The following is a description of a gene set: A series of reactions in which a signal is passed on to downstream proteins within the cell via HRI (also known as EIF2AK1), an intracellular protein kinase that is activated by stress signals, such as heme deficiency, oxidative stress, osmotic shock, mitochondrial dysfunction and heat shock. species: Mus musculus Mouse Gene Set: GOBP_HRI_MEDIATED_SIGNALING, and this is the list of marker genes: Ddit3, Oma1, Atad3a, Eif2s1, Dele1 (NCBI Gene Id 72517), Atf4, Eif2ak1